The following is a description of a gene set: studied in species Homo sapiens Human Gene Set: ZHONG_PFC_C8_UNKNOWN_NEUROD2_POS_INTERNEURON from publication Zhong S, Zhang S, Fan X, Wu Q, Yan L, Dong J, Zhang H, Li L, Sun L, Pan N, Xu X, Tang F, Zhang J, Qiao J, Wang X (PMID 29539641), and this is the list of marker genes: KBTBD11, CCBE1, ACTN2, NEUROD6, MAP6, DEAF1, CPE, FOXP1, HIVEP2, SYT4, PALM, JAG2, NEUROD2, VSTM2L, SEMA3C, DTX1, USP32P1, NTRK2, LPL, EEF1A2, DOK5, UNC13A (unc-13 homolog A), MVD, ABLIM1, PIK3R1, CRYM, DOCK9, IGSF21, BHLHE22, PHYHIP, FASN (NCBI Gene Id 2194), CNTN1, RGS11 (NCBI Gene Id 8786), MT3, NPY1R, USP32P2, PENK, ADCYAP1R1, NECAB1, CAMK2N2 (NCBI Gene Id 94032), B4GALT2, SLA, MAPK8IP2, SYT7, FABP3, CAPNS1, DNAJB2, CHD5, CNTN3, SRM, MAPK11, CSRP2, CACNG8, STK32B, ALCAM, AUTS2, POU3F2, CYRIA, GAP43, R3HDM1, RBFOX1, NCALD, ARHGAP23, PLXNA4, CALN1, EPHB6, SPOCK1, KHDRBS3, NELL2, SCD, COPRS, CEP126, PLPPR1, FBXW7 (NCBI Gene Id 55294), PDXP, PPFIA3, SYNGR3, B3GAT1, DTX4, DUSP23, CACNA1A, PTPRK, SMARCA2, LHX2